The following is a description of a gene set: S1P1 pathway Human Gene Set: PID_S1P_S1P1_PATHWAY from publication Schaefer CF, Anthony K, Krupa S, Buchoff J, Day M, Hannay T, Buetow KH (PMID 18832364) species: Homo sapiens, and this is the list of marker genes: PTGS2 (NCBI Gene Id 5743), RAC1, KDR, ITGB3 (NCBI Gene Id 3690), VEGFA, ITGAV, GNAI3, RHOA, GNAI1, MAPK3, GNAO1, ABCC1, PDGFB, S1PR1, GNAZ, GNAI2, SPHK1, PLCB2, PLCG1 (phospholipase C gamma 1), MAPK1, PDGFRB